Given this list of marker genes ARHGAP18, SMC6, ZMIZ1 (NCBI Gene Id 57178), ZNF414, TPD52, ISOC1, GOLM1, SOS2, KHDC3L, TM6SF1, IL6ST, TRAPPC1, ATXN1L, ANG, AKR1A1, OXT, ALPK1, RALB, SDF4, SYNE3, PEX11A, TNFRSF14, AZIN2, TBC1D13, ABI2, EML6, PRKRA, HSD17B4, MS4A2, PLEKHG3, IKBIP, STAT6 (NCBI Gene Id 6778), F5, KLF9, PYCARD, RGMB, ZC2HC1A, FUOM, MIB2, CERS5, TJP2, SGTB (small glutamine rich tetratricopeptide repeat co-chaperone beta), NHERF1, PLSCR1, TMEM50B, CD44, STX6, COPG1, B3GALNT1, MTA1, LYST, ISCU, COPRS, GSDMD, TMPO, INPP5B, OXR1, ATOX1, RPL10, GATAD1, DNAJC4, CNIH4, AJUBA, AP5Z1, TMEM9B (NCBI Gene Id 56674), FARP2, RAB11B (RAB11B, member RAS oncogene family), LRRK1, CCDC88B, UBE3B, OSTM1, EBI3, NUDT4, ERRFI1, SMPD5 (sphingomyelin phosphodiesterase 5 (pseudogene)), MEOX1, KCNK6, JAK2, LIMS4, PKM, ABCD1, SLC7A3, CYB5R1, NMT1 (NCBI Gene Id 4836), ITPK1, ARRB1, FST, SNX14, CYP27A1 (cytochrome P450 family 27 subfamily A member 1), MCTP1, C1orf216, SSR3, OSBPL8, RAP1B, EPB41, VAMP3, AGTRAP, RECK, RBM47, DSE, PDCD6IP, SLCO2A1, PLEKHJ1, RTN3, PPM1J, CASK, MX2, SLC15A3, VPS26C, TXNDC17 (thioredoxin domain containing 17), SFT2D2, RTP4, NSMAF, GBP6, DSTYK, CSNK1E, NCK1, ORAI1, GUSB, PDE2A, ST3GAL4, MAP1LC3B, HSD17B12, F13A1, PTGIR, PIGX, KIF13A, CTDSP1, RCN2, TNIP1, SEPTIN2 (septin 2), NCEH1, SPRY2, RIT1, TLR7, SLC66A3, TNS3, S100A1, FAM168A, IPMK, THYN1, DAGLB, PURG, CMKLR1, ANXA4, UNC119, DHRS4, RAF1, NUDT13, MCCC2, SH3GLB1, CFB, GATA2, PRKAB1 (NCBI Gene Id 5564), RAB7A, DNAJC3, GOSR2, HOXB4, SKP1, NRIP1, MARCHF2, SLC25A35, NLRC5, CITED4, FAAP100 (NCBI Gene Id 80233), CNDP2, CD3D, MID1IP1, HOMEZ, MIR22HG, GLTP, RAB39B, FTL, SPOP, TNS4, NCOA1, MBNL2, QPCT (NCBI Gene Id 25797), CMPK1, BMPR2, CHMP4B (charged multivesicular body protein 4B), G6PD, INPP1, ARHGAP23, DBI, KHK, ACVR1, PLA2G15, TUBB2A, FRMD4A, SMC5, ACSL5, RAB14, ADIPOR1, EMP3, CLN6, POGK (NCBI Gene Id 57645), LRRC8D, VPREB1, SLCO3A1, here is a description of the gene set: from publication Konuma T, Nakamura S, Miyagi S, Negishi M, Chiba T, Oguro H, Yuan J, Mochizuki-Kashio M, Ichikawa H, Miyoshi H, Vidal M, Iwama A (PMID 21540074) Each fraction of mouse hematopoietic cells was purified by cell sorting from bone marrow of 8-week-old C57BL/6 mice, and its gene expression was analyzed. Human Gene Set: GSE27786_BCELL_VS_NKCELL_DN Genes down-regulated in comparison of B cells versus NK cells. studied in species Homo sapiens